The following is a description of a gene set: Human Gene Set: GSE20727_CTRL_VS_ROS_INHIBITOR_TREATED_DC_DN Genes down-regulated in dendritic cells: untreated versus diphenyleneiodonium (DPI). from publication Miyazawa M, Takashima A (PMID 22974541) Identification of ROS induced genes on dendritic cells Dendritic cells were incubated for 15 min with or without a ROS inhibitor (DPI), washed extensively and incubated for 30 min with a chemical allergen (DNFB), hydrogen peroxide, and vehicle alone in HBSS containing DPI or vehicle. After washed extensively, the samples were post-incubated for 5.5 h with DNFB, hydrogen peroxide, or vehicle in complete culture medium containing DPI or vehicle. studied in species Homo sapiens, and this is the list of marker genes: RAD23B, UBE4A, FAM53C, FMO1, KIR3DX1, TRAM2, APOBEC3D, PTPN23, CCDC28A, ESCO2, CD38, DUSP5, MAU2, ADD1, ZCRB1, GAB1, CENPE, PIGT, MYBL2 (NCBI Gene Id 4605), TBC1D2, SUSD1, CBR1, SPATS2L, SRGN (NCBI Gene Id 5552), IGKC, WIPI1, AQP3, ACP2, MUL1, JCHAIN, BCL9, ACTB, TESPA1, TMED2, HM13, PIM1 (NCBI Gene Id 82453), BUB1, PLK2 (NCBI Gene Id 10769), SLC16A10, BUD13, NDUFB3, DCLRE1A, BIN2, TJP2, GPAA1, MYB, ATP11A, SORBS2, MPC2, SLC39A8, HSPA4, MPDU1, SLC43A3, WARS1, ANXA2P2, ATP8A2, SEPHS1, PNOC, ITGAL, PCTP, CENPU, RALY, CORO1A, ELL2, GTF2I, DAXX, WSB2, CITED2, SLC25A45, SEC61B, ICAM2, UQCRFS1, MLF2, CAMK4, PIP5K1P1, RAE1, TMEM104 (transmembrane protein 104), ZBED2, SNRPD2, ASPM, NSUN7, GNG2, POP1, SEC24D, PRKCD, RHOQ, GLT8D1, UBE2R2, TCL1A, XBP1, RRM2, RCBTB2 (RCC1 and BTB domain containing protein 2), PRDX5, IRF4, SLC9A7, PRELID1P6, ZBP1, SERPINB1, ARPC5, SPTSSA, RAD51, DRAP1, HPGD, RRH, SCD, PCED1B, UBXN10, PRR11, ITGAX, MAN1A1, TRIB1, CDV3, DBI, PGAP2, RNFT2, NRG4 (neuregulin 4), NAPA, NOCT, DOT1L, PFN1P2, LAMTOR2 (late endosomal/lysosomal adaptor, MAPK and MTOR activator 2), TGM2, COX7A2, GAPDH, TXNDC11, OSTC, NRBP1, SPRING1, TOP2A (NCBI Gene Id 7153), RANBP10, CHAD, NOP10, SEC61A1, LILRB4 (NCBI Gene Id 11006), ARID5A, RGCC, EDEM2, SLC25A11, TOP3A, IGHV4OR15-8, PLAGL2, NAPSA, TADA3, ALDH1L2, ASPHD2, PCNT, RCC2, CBLL1, SELPLG, VANGL1, SHMT1, TNFRSF17, XKRX, VDR, APOBEC3G, CD226, SELENOS, CAPZB, AAAS, JAKMIP1, COPE, CASP3, SEMA4A, MRTFA, POLR1D, CPSF7, TTC4, CIAO2A, PRDM1, MANEA, SLCO3A1, SLC38A5, ULK3, SUCLG1, ACAA2, PREB, BCKDK, SLAMF7, RBBP4, YIPF1, LTK, COQ5, RFTN1, STT3A (STT3 oligosaccharyltransferase complex catalytic subunit A), P4HB, VDAC1, CPSF1, FAM81A, RHOC, CDC25B, CCNB1, LAP3, JPT1 (NCBI Gene Id 51155), TSPAN18, GCSAM, CDCA7L (NCBI Gene Id 55536), FHL1, RBM47, POMP